The following is a description of a gene set: Cytokines mediate cell-cell communication in the immune system and represent important therapeutic targets. A myriad of studies have highlighted their central role in immune function, yet we lack a global view of the cellular responses of each immune cell type to each cytokine. To address this gap, the authors created the Immune Dictionary, a compendium of single-cell transcriptomic profiles of more than 17 immune cell types in response to each of 86 cytokines (>1,400 cytokine-cell type combinations) in mouse lymph nodes in vivo. A cytokine-centric view of the dictionary revealed that most cytokines induce highly cell-type-specific responses. For example, the inflammatory cytokine interleukin-1β induces distinct gene programmes in almost every cell type. A cell-type-centric view of the dictionary identified more than 66 cytokine-driven cellular polarization states across immune cell types, including previously uncharacterized states such as an interleukin-18-induced polyfunctional natural killer cell state. Mouse Gene Set: CUI_CDC2_TNFA_RESPONSE_DN from publication Cui A, Huang T, Li S, Ma A, Pérez JL, Sander C, Keskin DB, Wu CJ, Fraenkel E, Hacohen N (PMID 38057668) Genes negatively differentially expressed in cell type: cDC2 (conventional dendritic cell type 2) upon treatment with cytokine: TNF-α in mouse lymph nodes in vivo. species: Mus musculus, and this is the list of marker genes: Fbrsl1, Ltb4r1, Ssh2, P2ry6, Anp32a, Ppfia4, Dipk1a, Mmp12, Atp5if1, Rnd3, Hexa, Fuca1, Tifab, Raph1, H2-DMb1, Bcl11a, Gdi2, Naga, Lpin1, Dpy19l1, Aph1c, Itgb7, Snhg12, Hexb, Cdk14, Smpdl3a, Ank, Rnase6, Stk10, Me2, Hpgd, Cyb5a, Dguok, Zfp36l2, Tet3, Lrrc25, Cox7a2l, Plbd1, Neat1, Hspa1a, Tsc22d4, Fxyd5 (FXYD domain-containing ion transport regulator 5), Rassf4, Lat2 (NCBI Gene Id 65021), Arhgap39 (NCBI Gene Id 28124), Rnf166, Add3, Csf1r, Pld4, Naca, Bin2, Cd300c2, Mapk14, Anxa6, Gpi1, Otulin, Cyth4, Lmo4, Cd180, Selenop, Egr1, Ifitm6, Zbtb20 (zinc finger and BTB domain containing 20), Tmem50a, Gns, Hsd17b11, Gpr141, Slamf8, Shtn1, Tiam1, Myo1f, Slc12a9, Map3k4, Ptpre, Ncoa1, Hps3, Samhd1, Fgd2, Myl12b, Nfam1, Epsti1, Tmem238, Nedd9, Wdfy2 (WD repeat and FYVE domain containing 2), Pink1, Daglb, Lpxn, Inpp5k, Khk, Cd300a, Bnip3l, Eif4b, Man2b1, Smad7, Ncf2, Fam111a, Wls, Prcp, Srpk2, Slamf7, Pold4, Tecr, Bckdha, Txnip, Surf1, Adss1, Eif3h, Smim14, Stk17b, 9930111J21Rik2, Celf4, Fgl2, Higd2a, Mapk3, Eef2, Cited2, Sirpb1c, Tmsb10, Sh2d3c, Ier5, Dhrs7, Calhm2, Acox3, Wasf2, Slc66a2, Unc93b1, Arsb, Cd33, H2az2, Dock2, Macf1, Sfxn3, Slc48a1, Bri3, Ttc3, Il6ra, Akr7a5, Gm2a, Sla, Themis2, Ifngr1, Arhgap15, Usf2, Cat, Tkt, Klf4, Prr5l, Ccnd1, Cd300ld, L1cam, Zfp710, Pycard, Lrp1, Psme2b, Emilin2, Eif3e, Npm1, Adcy7, Cd68, Amz1, Ppa2, Clec4a1, Ssbp3, Tmem59, Ethe1, Ctss, Jund, Slc35c2, Rgs10, Ffar4, Zfp385a, Lmo1, Ncoa3, Ms4a6c, Hmgb1, Irag2, Inpp5d, Zeb2, Nr4a1, Iqgap2, Foxp1, Entpd1, Tep1, Ptp4a2, Tgfb1, Celf2 (CUGBP, Elav-like family member 2), Marchf1, Tnfrsf13b, Vrk1, Abcg1, Calhm6, Tm6sf1, Hfe, Lgals3, Rnf150, Dna2, Fau, Arhgap9, Eif3m, Rtraf, Susd3, Cyp27a1, Snx29, Nav1, Mgat1, Ptprc, Dek, Sms, Dctpp1, Scp2, Tut4, Hhex, Emb, Arhgdib, Parp8, Gpsm3, Lamtor4, Stard9, Borcs6, Uba52, Il10ra, Ptpn18, Sat1, Ubb, Spns3, Kdm7a, Arhgap17, Eid1, Ccr2, Rbfa, Gltp, Csk, Igbp1, Pgap1, Atf3, Hes6, Npc2, Sptssa, Evl (Ena-vasodilator stimulated phosphoprotein), Hk2, Tbc1d9, Haus8, Adgre1, BC028528, Mink1, Tnfaip8l2 (NCBI Gene Id 99931), Mbnl1, Plekho1, Mia2, Slc15a4, Epcam, Clec4a2, Ifitm3, Oxct1, Sirpb1a, Kctd12, Arhgef6, Nedd4, Pdcd4, Atp8a1, Fos, Laptm5, Trim12a, Mxd4, Itm2b, Ppp3ca, Lbh, Pik3cd, Bmyc, Hlcs, Arhgap45, Rasgrp4, Dgkd, Tcirg1, Cd72, Fosb, Stx16, Abcg3, Klhl24, Cd200r1, Furin, Pak1, Tent5a, Eif3f, Smarca2, Clic1, Nfatc2, Lmo2, Stard3nl, Camk1d, Clec4b1 (NCBI Gene Id 69810), Neurl3, Ear2, Plekhm3, Sgpp1, Nsa2, Arhgap25, Rsrp1, Dock10, Tifa, Plxdc1, Nap1l1, Unc119, Snapin, Ramp1, Erp29, Abca9, Fes, Eeig2, H1f2, Scd2, Rell1, Arl11, Rgs18 (regulator of G-protein signaling 18), Pstpip1, Bri3bp, Septin6, Hspa1b, Pglyrp1, Taldo1, Pid1, Lyl1, Btg2 (BTG anti-proliferation factor 2), Rnf130, Slc38a1, Smim5, Plekhg3, Dennd1b, Samd9l, Lst1, Rb1, Macroh2a1 (NCBI Gene Id 26914), Plin2, Ckb, G6pdx, Sorl1, Klf2, Dnajb14, Trappc5, Stap1, Alox5ap, Rack1, Jun, Slc43a2, Eno1, Mycbp2, Rere, Cd9, Exosc5, Mpeg1, Cnp, Nr4a2, Il16, Abhd17a, Lrrk2, H2-Oa, Fli1, Matk, Lta4h, Sp100, Mapre2, Idh2, Gsn, Ighm, Ubac2, Pip4p1, H2-DMa, Cox6b2, Cst3, Ypel3, Rgs2, Fnbp1, Skint3, Dnajc7, Cx3cr1, Anxa1, Ctdsp2, Slc46a3, Vsir, Arrb1, Ltb, Nfatc1, Psap, Tsc22d1, Grn, Gng2, Naaa, Coro7, Pdxk, Pals2 (protein associated with LIN7 2, MAGUK family member), Eif4ebp2, Igsf6, Nek7, Ccl6, Ndufa6, Ubl3, Mef2c, Otulinl, Sh2d1b1, Sulf2, Ehd4, Tpi1, Deptor